Given this list of marker genes GDF9, ROPN1L, IGHV3-74, LYG1, TMEM169, BOLA2B, LGALS12, UBAC2-AS1, RPL39L, IGLV8-61, SERPINB2, TPPP, TRAV16, here is a description of the gene set: from publication Hoek KL, Samir P, Howard LM, Niu X, Prasad N, Galassie A, Liu Q, Allos TM, Floyd KA, Guo Y, Shyr Y, Levy SE, Joyce S, Edwards KM, Link AJ (PMID 25706537) studied in species Homo sapiens Systems biology is an approach to comprehensively study complex interactions within a biological system. Most published systems vaccinology studies have utilized whole blood or peripheral blood mononuclear cells (PBMC) to monitor the immune response after vaccination. Because human blood is comprised of multiple hematopoietic cell types, the potential for masking responses of under-represented cell populations is increased when analyzing whole blood or PBMC. To investigate the contribution of individual cell types to the immune response after vaccination, we established a rapid and efficient method to purify human T and B cells, natural killer (NK) cells, myeloid dendritic cells (mDC), monocytes, and neutrophils from fresh venous blood. Purified cells were fractionated and processed in a single day. RNA-Seq and quantitative shotgun proteomics were performed to determine expression profiles for each cell type prior to and after inactivated seasonal influenza vaccination. Our results show that transcriptomic and proteomic profiles generated from purified immune cells differ significantly from PBMC. Differential expression analysis for each immune cell type also shows unique transcriptomic and proteomic expression profiles as well as changing biological networks at early time points after vaccination. This cell type-specific information provides a more comprehensive approach to monitor vaccine responses. Genes down-regulated in peripheral blood mononuclear cell 1d vs 0d in adults after exposure to Inactivated influenza vaccine, time point 1D. Comment: Down-regulated DE RNA transcripts (down >= 1.5x) shared between both TIV-vaccinated donors Human Gene Set: HOEK_PBMC_INACTIVATED_INFLUENZA_ADULT_1DY_DN